Given this list of marker genes GET1 (guided entry of tail-anchored proteins factor 1), GET3, EMC8, NOMO3, TRAM1, WNK1 (WNK lysine deficient protein kinase 1), NOMO2, MMGT1, EMC1, BAG6, NCLN, SGTA, EMC7, WDR83OS, EMC4 (ER membrane protein complex subunit 4), EMC2, EMC10, RAB5IF, EMC6, EMC3, CAMLG, TRAM1L1, TMEM147, GET4, TRAM2, UBL4A, EMC9, SEC61A1, TMCO1, NOMO1, CCDC47, here is a description of the gene set: studied in species Homo sapiens Human Gene Set: GOBP_PROTEIN_INSERTION_INTO_ER_MEMBRANE The process that results in incorporation of a protein into an endoplasmic reticulum (ER) membrane. It depends on specific topogenic sequences of amino acids that ensure that a protein acquires the proper orientation during its insertion into the ER membrane.